The following is a description of a gene set: studied in species Homo sapiens part of: Mitotic Prophase Reactome Pathway: MASTL Facilitates Mitotic Progression The activity of MASTL, also known as the Greatwall kinase (GWL), is necessary for the entry and progression of mitosis. MASTL is activated by phosphorylation of several key residues during mitotic entry. Phosphorylation on the serine residue S875 (S883 in Xenopus), likely through autophosphorylation appears to be critical. Several other sites, including putative CDK1 targets T194, T207 and T741, contribute to the full activation of MASTL. Other kinases, such as PLK1 and other MASTL phosphorylation sites may also be functionally important.<br><br>Activated MASTL phosphorylates ARPP19 and ENSA on serines S62 and S67, respectively, enabling them to bind to and inhibit the phosphatase activity of PP2A complexed with the regulatory subunit PPP2R2D (B55-delta). Inhibition of PP2A-PPP2R2D activity by ARPP19 or ENSA prevents dephosphorylation of CDK1 targets, hence allowing entry and maintenance of mitosis.<br><br>, and this is the list of marker genes: CDK1, ENSA (NCBI Gene Id 51620), PPP2CB, PPP2CA, PPP2R1B, ARPP19, CCNB1, PPP2R2D, PPP2R1A, MASTL